The following is a description of a gene set: studied in species Mus musculus Catalysis of the reaction: NADP+ + (5Z,13E)-(15S)-9-alpha,15-dihydroxy-11-oxoprosta-5,13-dienoate = NADPH + H+ + (5Z,13E)-9-alpha-hydroxy-11,15-dioxoprosta-5,13-dienoate. Mouse Gene Set: GOMF_15_HYDROXYPROSTAGLANDIN_D_DEHYDROGENASE_NADPPLUS_ACTIVITY, and this is the list of marker genes: Akr1c18, Akr1c20, Akr1c14, Akr1cl, Cbr1, Akr1c6